The following is a description of a gene set: species: Homo sapiens Human Gene Set: REACTOME_VIF_MEDIATED_DEGRADATION_OF_APOBEC3G Vif-mediated degradation of APOBEC3G, and this is the list of marker genes: ELOC, PSMA4, ADRM1, PSMC4, PSMA5, UBA52, PSMD14, PSMA2, APOBEC3G, PSMB1, PSMD1, PSMB3, PSMB7, PSMD3, PSMC5, PSMB6, SEM1, PSMD2, PSMA6, RPS27A, PSMB2, CUL5, ELOB, RBX1, PSMD13, PSMD11, PSMD8, PSMD6, PSMB5, PSMB4, UBC (NCBI Gene Id 7316), UBB, PSMC2, PSMC3, PSMA1, PSMA3, PSMC1, PSMD7, PSMC6, PSMA7, PSMD12